Given this list of marker genes PLBD1, PLA2G4B, PLA2G4C (NCBI Gene Id 8605), GPCPD1, PLA2G4A, PLA2G4E, PLA2G4D, PLA2G4F, PLA2G15, here is a description of the gene set: Reactome Pathway: Hydrolysis of LPC studied in species Homo sapiens part of: Glycerophospholipid biosynthesis Lysophosphatidylcholine (LPC) is hydrolyzed by phospholipases to produce glycerophosphocholine (GPCho) which is in turn hydrolyzed by glycerophosphocholine phosphodiesterase to produce choline (Cho) and glycerol-3-phosphate (G3P).